The following is a description of a gene set: Symphalangism of the 5th finger Fusion of two or more bones of the 5th finger. Human Gene Set: HP_SYMPHALANGISM_OF_THE_5TH_FINGER species: Homo sapiens, and this is the list of marker genes: BHLHA9, GDF5, NOG, TFAP2B, ROR2